The following is a description of a gene set: The directed movement of some substance from outside of a cell into a cell. This may occur via transport across the plasma membrane or via endocytosis. species: Homo sapiens Human Gene Set: GOBP_IMPORT_INTO_CELL, and this is the list of marker genes: GDNF, WASF2, SLC9C2, SLC38A2, RIN2, SLC7A8, SLC1A1, SNCB, CLEC4F, EHD3, ACTB, TAFA4, ITGAM, KCNE2, DRD4 (NCBI Gene Id 1815), ANGPT1, RHOV, PRKCE, SLC30A5, RAB21, SLC34A1, SH3KBP1, SLC22A1, CXCR2, SYNJ2, GSN, DLG1, TRPV5, ADIPOQ (adiponectin, C1Q and collagen domain containing), BIN1, FGR, ESYT2, P2RX7, XKR7, GPC3, PLA2R1, EFNB2, CALM3, AAK1, TSG101 (NCBI Gene Id 89764), SLC7A3, AQP8, SLC30A8, MYO19, TULP1, CD93, NCKAP1L, MKLN1, CLTB, SMPD1 (NCBI Gene Id 6609), PPP3R1, IL15RA, COLEC11, TMEM175, EPN2, LRRTM2, ARHGAP12, IL15, SLC22A2, WASF1, BICD1, P2RY6, MAPK3, VAMP7 (NCBI Gene Id 6845), RAB3B, INPP5F, MX2, RALBP1, RAB4A (RAB4A, member RAS oncogene family), RAB20, ACKR3, MYO6, NEURL3, CXCL16, NDP (norrin cystine knot growth factor NDP), SLC9A4, SLC5A2 (NCBI Gene Id 6524), SLC12A5, SLC24A4, ENTHD1, CD300LF, IFNG, TREX1, SLC6A11, SLC1A5, APP, CSNK1D, CD151, PCSK9, SLC27A1, CTSL, PTX3, VEGFA, KCNJ16, BLTP1, IGF2R, RAB14, GPR107, PI4KB, RAB9B, PLA2G5, LY75, ATG5, TNK2, GATA2, EPN3, SLC9A5, ARF6, RHOQ, RAMP2, SLC2A5, ITSN2, CACNA1H, SNAP25, GREM1, WDR54, EEA1, SLC3A2, SPON2, MTMR2 (myotubularin related protein 2), MIR448, LRP1, LMAN2, C2, PLCG2 (phospholipase C gamma 2), AP2A2, AP2S1, AP3D1, LCN2, SNX33, KCNH2, CACNA1D, HIP1, EQTN, SLC38A3, CD14, ITGB2, FCHO1, EPS15L1, NR1H3, HCN4, SLC9C1, HRAS, SYP, EHD1, LDLRAD3, SYT17, C1orf43, ATP8A1, CLEC10A, PPP3CA, TRPV6, TRPM4, ANXA2, JMJD6, APPL2, LMBRD1, FYN, SLC22A3, TRPM2, PSEN1, LIPA, TBC1D24, XKR8, ADGRB1, RACK1, PEAR1, SLC15A1, CAV3, HCN2, ACSL5, SLC7A2, LEP, CAV2, CAMK1D, STAT3, DNM1L, ABCC8, RAMP1, ICAM3, NECAP2, USP20 (NCBI Gene Id 10868), ADRB3, PLLP, MYO5C (myosin VC), MAPK1, DRD2, ELMO2, ARRB2, CLCN3, NOS2, STRA6, SYT4, STAB1, SYNRG (NCBI Gene Id 11276), REPS1, ITCH, SYT11, ANXA11, MSR1, DMBT1, C9orf72, BIN2, KCNJ13, SYNGR3, SEPTIN2, CANX, SLC48A1, KCNJ1, GRK2, NHERF1, GRM1 (NCBI Gene Id 2911), ARPC3, PACSIN2, ALOX15, PER2, TICAM2, RAB5A, STX1B, SCARA5, FNBP1, DKK1, HSPG2, SNX17, APOC3, DENND1B, SNX10, PRKCD, B2M, AMPH, MST1R, CNTN2, CLTC, SLC8A2 (NCBI Gene Id 6543), SLC12A6, PIP4P2, MIR24-1, SLC39A10, DENND1C, MYO1C, SCRIB, TNF, FPR2, SLC6A1, PLD2, HCK, ANKRD13D, SLC6A5, MIR200C, ATXN2, CBLL1, AZU1, ABL2, COLEC12, CALCRL, ANXA2P2 (NCBI Gene Id 304), MIR210, VAC14, DNAJC13, RAC1, ITSN1, CCR7, MESD, SLC15A4, MYO18A, SLC5A1, MAPKAPK3, LMBR1L, USP33, VIPAS39, ARAP1, KIAA0319L, XKR6, ELANE, XKR4, RINL, ATP1A2, ASGR1, ZFYVE16, SLC8A1, NTF3, SLC30A1, SLC8A3 (NCBI Gene Id 90450), CLU, KCNJ9, ATP1B2, THBS1, KCNQ3, EPRS1, SLC6A4, PIK3CB, MIR199A1, RAB22A, CLCN5, CD300A, RHOJ, ARHGAP25, SLC39A6, TUSC2, MYCBPAP, SLC5A6, ABCA2, PRKACA, ABCC9, CLINT1, STAP1, AP3S2 (NCBI Gene Id 8885), SH3GL1, LRP6, GSG1L, FCN1 (NCBI Gene Id 2219), OCIAD2 (NCBI Gene Id 132299), HEATR5A (HEAT repeat containing 5A), RIT2, NCF4, MX1, ISCU, MARCHF3 (membrane associated ring-CH-type finger 3), CDC42, OPHN1, NLGN1, GH1, CTBP1, SLC27A5, SLC46A2, PSTPIP1, LILRB4, PRKCG, SLC6A13, GULP1, SNX1, NECAB2, CREG1, ATP9B, UNC119, SLC39A4, PACSIN1 (NCBI Gene Id 57564), SHH, GRIA1, NUMB, RAP1GAP, LDLRAP1, PRKD1, MBL2, ANK2, TLR2, GFAP, CLN3, ATP6V1H, CXCR1, SDC1, DENND1A, CACNA1E, CEBPE, OPA1, CDH13, ABCA13, SLC7A1, SCAMP1, VLDLR, PYCARD (NCBI Gene Id 29108), SRPX, FNBP1L, CFP, LRSAM1 (NCBI Gene Id 90678), SLC6A3 (solute carrier family 6 member 3), MTMR6, SLC15A3, SLC29A1, LRRC8B, AHI1, PLXNB2, FCER2, ACTG1, LRP3, C4B, RAB5C, MYO1F, ANO6, CACNA1G, SLC18B1, RNASEK, LEPR, CYTH2, SLAMF1, NCF2, AP2A1, ATP1A4, ANKRD13A, SLC11A1 (NCBI Gene Id 6556), NOS1, ATP1A3, DRD3, SLC12A2, DNM3, ACE2, SFRP4, APOC1, SUSD4, SIRPA, UBE3A, ATP12A, ITGAV, RUFY1, PECAM1, IL2RB, IL4, CTTN, GPM6B, NCDN, AP3M2, EHD4, RABEP2, EEF2K, GHR, BCL2L1, KCNQ1, CARMIL1, ARHGAP27, SLC9A2, ATG3, RAB9A, CLTRN, EPHA3, SLC36A4, AP3S1, LIMK1, ARL6IP1, ARF1, CSNK1G1, NLGN3, SLC9A9, HMGB1, RAB1A, LETMD1, SLC18A3, ARL8B, RABGEF1, KCNJ6, BTBD8, TRPV1, KCNK5, LRRC8E, MERTK, SCNN1A, AP1G1, KCNJ3, ELMO1, DNAJC6, VAV2 (vav guanine nucleotide exchange factor 2), CYBA, MYO1H, ANKFY1, RAB27B, MIR30D, SCAMP5, BECN1, CSK, CLIP3, STK39, SMAP1, CCDC32, PIP5K1A, ACSL1, SCARF1, PPP3CB, HMMR, DYSF, ASIC5, DLG4, PRTN3, IRF8 (NCBI Gene Id 3394), LPAR1, CCR2 (C-C motif chemokine receptor 2), TLR4, LGALS3, VTN, TGFB1 (transforming growth factor beta 1), SLC6A7, HFE, SLC27A2 (NCBI Gene Id 8523), CDC42SE2, CACNA1C, CNN2, MFGE8, SLC27A4, F2RL1, FKBP15, TMEM108, SNX9, APOE, SGIP1, SCARB1, SLC46A1, PIK3CA, KCNJ4, SLC9A7, SLC39A11, RABEP1, SYT7, HAMP, LRRC8A, PAK1, ROCK1, RAB4B, LRP8, TGM2, MDM2, REPS2, CCL21, SLC12A4, CAV1, PARK7, SLC6A20, SLC28A1, ARRB1, LYN, AP2M1, DNM1, LYST, UNC13D, SLC43A1, STX1A, PIK3CG, DGKD, H1-1, STEAP2, VAV3, TUB, CRYBA1, DLL1, CALCA, LRP10, TREM2, TOR1A, C4BPA, SIRPG, EZR, ADORA1, AKAP5, FCGR1A, C4BPB, CBL, RALA, PACSIN3, AXL, SLC22A4 (solute carrier family 22 member 4), FCHO2, HPCA, DTNBP1, FLOT1, CALR, SCNN1B (sodium channel epithelial 1 subunit beta), TF, ABCA7, SLC2A4, DNER, PPP3R2, P2RX1, CLEC7A, RGS4, SNCG, APLP1, SPX, NPC1, MIR17, ITGB3, ITGAL, CORO1A, LRRK2, RABEPK, SLC24A2 (NCBI Gene Id 25769), SH3BP4, STAB2, KCNJ12, CALY, APLNR, RARA, ADM, ITGA2, CD47, SERPINE1, IGHE, ATP4A, ABL1, CLTCL1, PDLIM7, CUBN, ARR3, BIN3, FCGR2C, CLN8, UBQLN2, CLCN2, FCN3, SCARB2, SFTPA1, TOM1, SLC6A9, DAB2, SAG (S-antigen visual arrestin), MYO7B, CACNA2D1, SORL1, SH3GL2, FCGR2B, NALF2, GAPVD1, SIGLEC1, MYO1B, EHD2, SLC5A3, CNGA3, LRPAP1, AIF1, MIR92B, ACSL3, SLC18A2, GRK3, MS4A1, PTPRC, MARCO, SLC2A3, LRRTM1, SCYL2, SLC1A3, VAV1, KCNJ18, SH3BP1, FXYD2, RAB11FIP2, HGS, SIRPB1, LYVE1, RIN3, CXCL8 (NCBI Gene Id 3576), EGF, MAGI2, FCGR2A, SHOC2, ADORA2A, SCNN1G, MIR181B1, CLEC4M, ACHE, CD63, KCNJ2, ELMO3, WNT3A (Wnt family member 3A, NCBI Gene Id 89780), RHOU, CACNA1I, VPS33B, ANKRD13B, PTK2, NEDD4L, MYO5B, SLC24A1, SLC6A14, FCN2, SLC39A5, PICALM, MIR26A1, CD81, MYO5A, TSPO2, DRD1, ITGA4, ARC, GAS6, KCNJ15, CD302 (NCBI Gene Id 9936), MIR183, RAP1A, SYNJ1, RSPO1, IL2RG, TRIP10, TRPV2, SNAP91, CD9, SLC36A1, KCNJ11, SNX18, MLC1, MIR103A1, LRP1B, DOCK1, SNX12, DPYSL2, RNF220, FCMR, IL10RA, MIB1, CLTA, BCR, STON2, HEATR5B, PTPN1, DPP4, CSNK1G3, SPG11, MICALL1, WNT5A, EPN1, SYK, PIK3C2A, SLC29A2, SLC6A6, RALB, HCN3, CAPN2, YES1, CCL2, ATP2B4, ATAD1, AP2B1, USH1G, CLEC9A, AP1S1, RAB7B (NCBI Gene Id 84855, RAB7B, member RAS oncogene family), MYO1D, PRKN, MYO1E, DBNL, MRC2, APOA1, SFTPD, CSNK1E, HIP1R, KCNJ10, TRPM1, TM9SF4, LRRC8C, SELE, SLC15A2, ATP1B3, EPS15, PLA2G6, MYO15A, KCNJ8, CD22, CD177, HAVCR1, SLC9A6, SLC9A3 (solute carrier family 9 member A3), USP6, RAB39A, CBLB, C4A, NOSTRIN, RUFY2, KCNJ5, ICAM5, LRRC8D, SLC39A14, NEDD4, RIN1, SLC39A8, FOLR1, SLC39A12, ITGB1, CEACAM4, TYRO3, CSNK1G2, ASGR2, AP3M1, ATP9A, SLC47A1, SLC6A12, DNM2 (NCBI Gene Id 338330), TSC2, DOCK2, LYAR, FCER1G, TPCN2, RAB31, SLC12A3, RUBCN, JOSD1 (Josephin domain containing 1), OCIAD1, PIKFYVE, MCTP1, EIF2AK1, SLC19A1, RAB34, RABGAP1L, CD209, NTSR1, HOOK2, INSR, SLC12A7, FABP3, GRK4, AGER, SDCBP (NCBI Gene Id 6386), SLC38A1, SH3GL3, LRP12, INPPL1, FCHSD2, AKT1 (AKT serine/threonine kinase 1), MYD88, RBP4, CDK5 (NCBI Gene Id 1020), MYH9, APLN, CACNA1B, SLC6A2, DGKQ, NRG1, M6PR, BTK, SLC12A8, SLITRK1, RPS6KB1, ADRB2, MIR205, GRB2, PTPRJ (NCBI Gene Id 5795), FMR1, SPHK1, SLC38A4, BTBD9, PICK1, NECAP1, AP3B2, WASL, MRC1, SLC7A11, CALM1, RAMP3, SLC18A1, TIMD4, ARL6IP5, IRS2, PPP3CC, APELA, CALM2, MIR20A, AHSG, ARFGAP1, VAMP2, LRP5, ENTREP1, MAPKAPK2, SRC, CDC42SE1 (NCBI Gene Id 56882), PRNP, TBC1D5, SNX3, RAB27A, SLC12A1, CORO1C, CRP, SLC17A7 (solute carrier family 17 member 7), SLC38A5, RAB15, ATP4B, GRM6, AKT2, PIK3C3, SLC1A2, C3, LILRB1, SLC1A7, PLPP4, PPT1, TRPV4, RAB7A, LDLR, HCN1, NR1H2, SLC17A8, MYO1A, SLC27A6, SLC9B2, COLEC10, NEU3, MYO1G, KCNN4, SLC1A4, CCL19, CACNA1S, SLC16A2, SPACA3, MTMR9, CAP1, APOA5, TRPV3, MIR27B, MYLK, APOA2, SLC1A6, SYNJ2BP, NEURL1B, CD36, CACNA1F, KCNK9, TBC1D2B (NCBI Gene Id 91449), SLC29A4, EHBP1 (NCBI Gene Id 23301), KCNJ14, PIP5K1C, MIR208B, VAMP4, SLC2A10, GAS7, ATP1A1, SLC43A2, ANXA3, BMP2K, CACNA1A, ZFYVE9, SOD1, LRP2, MARCHF2, FCGR1BP, AMN (NCBI Gene Id 81693), MEGF10, RGS2, NCKIPSD, NALF1, SORT1, P2RX5, ANXA1, MYO7A (myosin VIIA), LRP4, PLD4, SLC2A1 (NCBI Gene Id 6513), CEACAM1, TYROBP, SCNN1D, RAB5B (NCBI Gene Id 5869), ATP1B1, MIR185, NME1, GTF2H2, APPL1, TFR2, SLC7A5, LBP, SNCA, SLC9A1, MIR208A, VPS28, SNX5, USP46, PROM2 (prominin 2), PLSCR1, GAK, APOC2, TFRC, STON1, ABCA1, TAMALIN